The following is a description of a gene set: Human Gene Set: HP_ABNORMAL_SWEAT_GLAND_MORPHOLOGY studied in species Homo sapiens Any structural abnormality of the sweat gland. Abnormal sweat gland morphology, and this is the list of marker genes: RPL21, MSX1, IKBKG, ZMPSTE24, TBX3, EPS8L3, KRT71, HOXC13, KRT74, SOX18, TP63, LMNA, ZNF141, NTRK1, NFKBIA, KDF1, KRT85, EDA, KRT14, LIPH